The following is a description of a gene set: Any process that stops, prevents or reduces the frequency, rate or extent of calcium ion transmembrane transporter activity. studied in species Homo sapiens Human Gene Set: GOBP_NEGATIVE_REGULATION_OF_CALCIUM_ION_TRANSMEMBRANE_TRANSPORTER_ACTIVITY, and this is the list of marker genes: CALM3, CACNA1F, GNB5, FMR1, CALM2, CALM1, PLN, UBQLN1, GPR35, SLN, TLR9, CBARP, CRHR1